Given this list of marker genes TCF7L2, GPR45, FCAR (NCBI Gene Id 2204), SH3PXD2A, WASHC4, SMAP1, NRF1, CA9, CD164, PPP1R2C, SCG2, CLDN14, H2AC13 (H2A clustered histone 13), HAAO, SYT2, MAFK, CDHR1, CRTAM, KMT2D, ASTN1, RRP15, ADIPOQ, FKBP8, RORC, LINC03124, EPHX2, MMRN1, TM4SF4, DSC1, KCNJ9, ALPL, KRT15, MYLK, FOXO4, CACNA1E, H3C10, ABCB4, ZNF135, SPON1, LGALS2, MSTN, SMR3B, MEIS2, SERPINA6, SDC2, CACNA1B, RPL39L, FOXI1, INHA, CIR1, SSX5, AMPD1, TNPO2 (NCBI Gene Id 80048), LINC00302, NACAD, DUSP5, PLG, ATRNL1, MN1, RLN2, PDE9A, SPAG6, ETV4, CPA3, C8G, LOXL2, DBF4, SPATA31F2P, APOD, ANKRD28, APOF, BMP8A, CDC5L, MADCAM1, COX6B1 (cytochrome c oxidase subunit 6B1), ITGAD, ZNF507, SLC29A2, ACRV1, RRAD, GRM8, SPDEF, CACNG1, ERLIN2, GRAMD1B, GPM6B (NCBI Gene Id 2824), OXT, AP1S1, GJC1, EOLA1-DT, CACNG3, GBX1, MACROH2A1, PTPN2, H2AC12, TMSB10, CLIP3, YLPM1, EYA2, B3GAT2, DNAH3, B4GALT5, OR1E1, HOXA2, CDC42EP1, TNFSF12, TMEM262, PPY, NT5E, NLGN4Y, FBXL2, CES2 (carboxylesterase 2), GFAP, MCAM, DKK1, NOTCH3, GSTZ1, GUCY2D, XYLB, ADCY8, KIF5A, AADAC, APOC2, RHAG (NCBI Gene Id 6005), CFP, MXRA5, SLITRK5, PTCRA, SPAM1, ASIC1 (NCBI Gene Id 41), OPRD1, KISS1, SPTLC2, ANXA9, GRIA3, TLR5, REG3A, TULP2, KCNG1 (potassium voltage-gated channel modifier subfamily G member 1), SOX1, FCN1, TBC1D12, GABRA6, SPP2, IPO13, SORBS2, GNRH1, GARS1, G6PC1, TRIB1, TNNT2, ADAM18, MYL11, HPGDS, SLC1A5, EFS, TRAT1, TPM4, CTNNAL1 (NCBI Gene Id 8727), CTNNA2, EXOSC9, RNASE2CP, KRT8, ENTPD5, LEFTY2, FOXG1, OVOL2, GLRB, ZNF165, PIP, ZNF749, SERPINI1, EMX1, RAD54L2, UBL3, DRP2, PNISR, APOBEC2, MCAT, KLK11, ZKSCAN1 (zinc finger with KRAB and SCAN domains 1), CASR, C8A, VWA8, RBFA, KCNB1, VIPR1 (vasoactive intestinal peptide receptor 1), CD101, SULT2A1, SF3B3, RRH, UBE2H, KTN1, GABRR2, EPN2, MAPK12, SYDE1 (synapse defective Rho GTPase homolog 1), MYH8, USP6, here is a description of the gene set: Monocyte-derived dendritic cells (DC) and macrophages (MΦ) generated in vitro from the same individual blood donors were exposed to five different pathogens, and gene expression profiles were assessed by microarray analysis. Responses to Mycobacterium tuberculosis and to phylogenetically distinct protozoan (Leishmania major, L. donovani, Toxoplasma gondii) and helminth (Brugia malayi) parasites were examined, each of which produces chronic infections in humans yet vary considerably in the nature of the immune responses they trigger. Human Gene Set: GSE360_L_MAJOR_VS_T_GONDII_DC_UP from publication Chaussabel D, Semnani RT, McDowell MA, Sacks D, Sher A, Nutman TB (PMID 12663451) Genes up-regulated in comparison of dendritic cells (DC) exposed to L. major versus DCs exposed to T. gondii. studied in species Homo sapiens